Given this list of marker genes SLC12A2, SLC12A7, SLC12A1, SLC12A5, SLC12A6, SLC12A3, SLC12A4, here is a description of the gene set: part of: SLC-mediated transport of inorganic anions studied in species Homo sapiens Reactome Pathway: Cation-coupled Chloride cotransporters The cation-chloride cotransporter family (SLC12 gene family) are membrane proteins that cotranslocate chloride (Cl-) with either Na+, K+, or both cations electroneutrally. The general topology of these proteins feature 12 transmembrane domains flanked by hydrophilic NH2 and COOH-terminal domains. They are secondary transporters and movement of these cations is determined by gradients established by primary transporters such as Na+-K+-ATPase. Cotransporters that use Na+ as the driving force move Cl- into the cell because Na+ concentration is higher in the extracellular region. Conversely, cotransporters that use K+ as the driving force move Cl- out of the cell because K+ concentration is higher inside the cell.<br><br>The SLC12 gene family contains nine members, of which seven are clearly characterized genes and two are orphans. They encode cotransporter proteins which are 1) involved in Cl- homeostasis, 2) regulate cell volume, 3) involved in transepithelial ion movement (salt reabsorption in the kidney) and 4) involved in response to neurotransmitters such as GABA. <br><br>Three different cotransporter subtypes are expressed by the seven characterized genes; one thiazide-sensitive Na+/Cl- cotransporter, two loop diuretic-sensitive Na+, K+/2Cl- cotransporters and four K+/Cl- cotransporters (Gamba G, 2005; Hebert SC et al, 2004).